The following is a description of a gene set: studied in species Homo sapiens Human Gene Set: GSE16522_ANTI_CD3CD28_STIM_VS_UNSTIM_MEMORY_CD8_TCELL_UP Genes up-regulated in comparison of stimulated memory CD8 T cells from pmel-1 mice versus unstimulated memory CD8 T cells from pmel-1 mice. from publication Hinrichs CS, Borman ZA, Cassard L, Gattinoni L, Spolski R, Yu Z, Sanchez-Perez L, Muranski P, Kern SJ, Logun C, Palmer DC, Ji Y, Reger RN, Leonard WJ, Danner RL, Rosenberg SA, Restifo NP (PMID 19805141) Effector cells for adoptive immunotherapy can be generated by in vitro stimulation of naïve or memory subsets of CD8+ T cells. While the characteristics of CD8+ T cell subsets are well defined, the heritable influence of those populations on their effector cell progeny is not well understood. We studied effector cells generated from naïve or central memory CD8+ T cells and found that they retained distinct gene expression signatures and developmental programs. Effector cells derived from central memory cells tended to retain their CD62L+ phenotype, but also to acquire KLRG1, an indicator of cellular senescence. In contrast, the effector cell progeny of naïve cells displayed reduced terminal differentiation, and, following infusion, they displayed greater expansion, cytokine production, and tumor destruction. These data indicate that effector cells retain a gene expression imprint conferred by their naïve or central memory progenitors, and they suggest a strategy for enhancing cancer immunotherapy., and this is the list of marker genes: PSMD5, TIPARP, RSBN1, DNMT3B (DNA methyltransferase 3 beta), STK38L, CTH, PLEK2, FOXS1, RHBDD1, NAPA, SLA, YARS1, FBXL7, TMEM171 (transmembrane protein 171), IRAG2, FGF18, RND2, NDST2 (NCBI Gene Id 8509), TIMM50, ACACA, BFSP1, IARS1, UQCRQ, S100A5, ZNF286A, CRIP2, IGDCC3, MIR124-1HG, POLR1C, KIAA1958, LHFPL2, NFIX, CALU, PSMC6, LSM1, FAM83G, HSPA1B, NUDT5, PAPOLG, ZC3H12A, USP24, NAP1L1, SLC66A2, USP54 (NCBI Gene Id 159195), SLC13A3, FAM107B, MRPS22, NR4A1, CYB5R1, WFS1, ENC1, CSE1L, HNRNPLL, FBXO11, PYCR1, GLS2, CGNL1, IL10, KRIT1, UBE3C, RNF121, SRGAP3, PHOX2B, CASS4, SRGN, SBDS, MSMO1 (methylsterol monooxygenase 1), SPHK1, PEPD, TXNL1, UTP14A, FOXP1, TNFSF9, RASL11B, PGM3, CDYL, JAK2, FAS, RRAGD, SGMS2, CRYBG3, GOSR2, ORC1, NCS1, HAX1, ZSWIM4, MED17, RHBDF2, PSMD11, ZNF655, PRKCSH, AARS1, NMT2, RC3H1, TNS1, FEM1C, PDZK1IP1, PDCD2, CD9, ENKUR, RNF2, TUBB6, COG2, ESR2, MAP3K8, SLC38A1, NDST4, GPR50, NDRG1, KCMF1, ANXA2, FHL2, SHISA3, CKAP4, PRRT1, AREG, PLCXD2, SPTB, SLC6A2, WAPL, NSRP1, KDM1A, ADAT2, ADH4, CCDC180, LYPD8, KIAA0513, PRRG4, BCLAF3, SLC6A9, NHLRC2, CFLAR, CHRNA9, CNNM4, GMPS, KLRG2, GMEB2 (glucocorticoid modulatory element binding protein 2), CDK5R1, MEMO1 (NCBI Gene Id 63983), SCN1B, IPO5, PLAUR, CXCL16, SLC25A25, TMEM214, ATXN7L1, SNX11, RBMX, PPP2R3A, ZEB1, ZNF703, URM1, PDAP1, CTDP1, TULP4, DHX15, SF3A3, GALNT4, ATF7, DERL1 (derlin 1), TNF, CRISP2, MBP, TBL1X, MCOLN2, EMP1, HBS1L, CCNYL1, RUNX2, ACTL6A, PKNOX2, RPN1, KSR1, PALS2, SLC15A3, ASNS, SLC35E3, C11orf97, HAGH, PFDN6, PITHD1 (PITH domain containing 1), CCT4, USP33, STAT5B, EIF3L (NCBI Gene Id 51386), SRPK1, MMP13, EIF3C, TOP1MT, AHCYL2, GPT2, TBPL1 (TATA-box binding protein like 1), WNT11, CLCF1, MST1R, ALOX12, HSPB1, CLEC12B, PHF10, SLC41A1